The following is a description of a gene set: studied in species Mus musculus CUL7 binds to SKP1, RBX1, and FBXW8 to form a cullin-RING ligase, or an SKP1-cullin-F box protein complex. The targeted disruption of the Cul7 gene in mice results in significant reduction in embryo size and neonatal lethality. In humans, CUL7 was found to be mutated in the 3-M dwarfism syndrome characterized by severe pre- and postnatal growth retardation, indicating that CUL7 is closely associated with human and mouse growth. We generated mice lacking Fbxw8 by gene trapping. Similar to Cul7(-/-) animals, Fbxw8(-/-) embryos and placentas were smaller than wild-type and heterozygous littermates and placentas. Approximately 30% of the expected number of Fbxw8(-/-) mice survived birth, but these mice remained smaller than their wild-type and heterozygous littermates throughout postnatal development. FBXW8 expression was detected in most organs of wild-type mice examined, and the organs in Fbxw8(-/-) mice were smaller than those in wild-type mice. Fbxw8 expression levels were highest in skeletal muscle, cartilage, and lung tissue. Expression profiling revealed elevated levels of insulin-like growth factor binding protein 1 (IGFBP1) transcripts in Fbxw8(-/-) embryos. Furthermore, we observed increased levels of IGFBP2 in Cul7(-/-) as well as Fbxw8(-/-) fibroblasts. These results demonstrate that the FBXW8-CUL7 complex plays a significant role in growth control. from publication Tsutsumi T, Kuwabara H, Arai T, Xiao Y, Decaprio JA (PMID 17998335) Genes differentially expressed in E18.5 whole embryos upon knockout of FBXW8. Mouse Gene Set: TSUTSUMI_FBXW8_TARGETS, and this is the list of marker genes: Fbxw8, Igfbp1, Ryr1, Actn3, Mypn, Pcgf5, Mybpc2, Sfswap, Atp2a1 (ATPase, Ca++ transporting, cardiac muscle, fast twitch 1)